The following is a description of a gene set: Mouse Gene Set: GOBP_SERINE_FAMILY_AMINO_ACID_BIOSYNTHETIC_PROCESS studied in species Mus musculus The chemical reactions and pathways resulting in the formation of amino acids of the serine family, comprising cysteine, glycine, homoserine, selenocysteine and serine., and this is the list of marker genes: Tha1, Sephs2, Mthfd1, Cth, Agxt2, Phgdh, Psat1, Shmt2, Sephs1, Hao1, Agxt, Ggt1, Shmt1, Cbs, Psph